Given this list of marker genes Cirbp, Ywhaq, Cd8a, Bcl2a1b, Ly6c2, Krtcap2, Trps1, Aldoa, Capns1, Srgn, Lgals3, Glipr2, Prr13, Ly6a, Ctla2a, Clint1, Epsti1, Tmem254, Cd74, Anxa2, Klf6, Sh2d1a, Gm8369, Gimap7, H2-D1, Zmat5, Cldn25, Emp3, Ptprcap, Iqgap1, Junb (NCBI Gene Id 16477), Vim, Thy1, Serpina3g, Capg, Bhlhe40, H2az1, Neat1, Apobec3, Pglyrp1, Pdcd10, Tnfrsf18, Lime1, Lrp10, Ifi47, Scgb1a1, S100a4, S100a6, Tap1, Daxx, Smpdl3a, Ier2, S100a13, Actg1, Cd48, Psmb8, Slc3a2, Cd8b1, Tspo, Atp2b1, Cox17, Cyba (NCBI Gene Id 13057), Cdc42ep3, Itga4, Socs1, Lgals1, Pgam1, Dnaja1, 1810037I17Rik, Gna15, Ncf4, Cxcr6, Txn1, Id2, Runx3 (runt related transcription factor 3), Ptpn18 (NCBI Gene Id 19253), Pkp3, Cxcr3, Ccl5, Lpxn (NCBI Gene Id 319643), Lsp1, Ctla4, Vamp8, Ifi35, H2-Q4, Ms4a6b, Hcst, Gpr183 (NCBI Gene Id 321019), Ifngr1, Tbc1d10c, Plaat3, B2m, Hmgb2, Ppp1r12a, Tnfsf8 (NCBI Gene Id 21949), Cst7, Cd5, Sh3glb1, Ahnak, Tnfrsf4, Arf4, Smco4, Malat1, Dek, Tspan3, Vmp1, Rgs1, Gng2, Nkg7, Ndfip1, S100a11, Tmbim6, Ptpn11, Cd82, Clic1, Ifi203, Itgb1, Bst2, Sftpc, Socs3, Il10rb, Ciao2b, Selplg, AW112010 (expressed sequence AW112010), Psme1, Gbp7 (guanylate binding protein 7), Odc1, Itm2c, Ly6e, Ms4a4b, Reep5, Hspa8, Hsp90aa1, S100a10, Nr3c1, Crip1, H2-K1, Il2rb, here is a description of the gene set: Mouse Gene Set: TABULA_MURIS_SENIS_LUNG_CD4_POSITIVE_ALPHA_BETA_T_CELL_AGEING species: Mus musculus from publication Tabula Muris Consortium (PMID 32669714)